Given this list of marker genes FANCI, PRR12, PALB2, NXN (NCBI Gene Id 64359), SPTBN1, ROR2, FANCD2, FANCA, FANCF, FANCE, FANCC, FANCM, MAD2L2, RAD51C, BRCA2, WDR35, RAD51, FANCL, DVL1, FBXO11, PI4KA, FANCG, BRIP1, BRCA1, UBE2T, ERCC4, FANCB, SLX4, XRCC2, RFWD3, here is a description of the gene set: Underdevelopment or absence of the uvula. Aplasia/Hypoplasia of the uvula studied in species Homo sapiens Human Gene Set: HP_APLASIA_HYPOPLASIA_OF_THE_UVULA